Given this list of marker genes GNA15, DNAJC3, RIPK1, PPP4R3B, ADORA2A, COQ10A, OSBPL3 (NCBI Gene Id 26031), UBR2, MFAP3, GOLM1, TRAPPC4, PXMP4, DUSP2, TMEM62, MED13L, ZC3H11A, MBP, EMB, NIN, NCF4, FHIP1B, GARIN3, DPP8, F2RL2, SNTB2, CFLAR, FRAT1, EPC1, SUB1, HACE1 (HECT domain and ankyrin repeat containing E3 ubiquitin protein ligase 1), GNAL, CD53, RELL1, GCNT3, ERMP1, SIKE1, ACAP2 (NCBI Gene Id 23527), PGM2L1, GTF2A1, ST8SIA4, PYGO2, PRKCD, ITPKB, H2BC21, TMTC4, ZSWIM6, DNASE1L1, MFSD1, EDEM3, SLC35D2, ANTKMT, GNG10, MS4A7, COMMD10, AP3B1, CHMP1B, INSYN2B, TMF1, ARL4D, VPS28, RAP1GAP2, SECISBP2L, TMSB4X, MRPL33, DCP1B, POLK, PIK3C3, TAPBPL, TNFAIP3, DCTN4, ICE1 (interactor of little elongation complex ELL subunit 1), MAF1, EYA2, IRF1, SNX14, TNIK, DNAAF5, PLCB2, FCER1G, CYBA, FBXO25, ITPR2, RNF103, VPS41, RNF214, CEP97, STXBP2, CLEC2D, SYNJ1, CD28, ZMYM5, FBXL3, FUCA1, CYTH4, HS3ST3B1, LASP1, TMEM170A, CRYZL1, MPPE1, ICAM1, KDM5B, GPR160, GPX8, MOB1A, POLR3C, TAX1BP1, ZZEF1 (NCBI Gene Id 80238), LMBRD1, DNMT3L, LYN, DNAJB13, KRIT1, PHF21A, BBX, NFATC3, RABGAP1L, BRWD1, SIDT2, PFDN5, CXCR6, GNPDA2, AKT3, VPS26B, ITGAM, DPM2, GIMAP5, VRK3, SMPD2, ARL15, SSR3, KMT5B, SRGN, TCP11, CAPN1, INSIG2, MSRB1 (methionine sulfoxide reductase B1), SORL1, LRRC8C, ZDHHC20, UBAP1, IFIT2, TBC1D8B, SLC35B4, F2R, MXD4, ALDH3A2, ACD, CRTC3, SNAPC5, SLC2A3, B2M, SLC25A14, HP1BP3, GADD45A, SERINC1, RTN4RL1, AKIRIN1, PRKACB, STRADB, BCAS3, NDUFA1, TBCEL, TBC1D10C, C19orf38, ZMYND11, WDR7, FBXO4, VGLL4, CYB561A3, SSH2, TLN1, UIMC1, DYNC1I2, SERINC3, VPS37B, here is a description of the gene set: The goal of the study was to identify the effects of TGF-beta on primary human macrophages maturated under different conditions. studied in species Homo sapiens from publication Gratchev A, Kzhyshkowska J, Kannookadan S, Ochsenreiter M, Popova A, Yu X, Mamidi S, Stonehouse-Usselmann E, Muller-Molinet I, Gooi L, Goerdt S (PMID 18453574) Human Gene Set: GSE7568_IL4_TGFB_DEXAMETHASONE_VS_IL4_TGFB_TREATED_MACROPHAGE_DN Genes down-regulated in macrophages: 5 days with IL4 and dexamethasone followed by TGFB1 for 24h versus 5 days with IL4 followed by TGFB1 for 24h.